Given this list of marker genes CTCFL, MED13L, GNA13, LETMD1, ATP8A1, SLC39A10, UBE3A, LRRC15 (leucine rich repeat containing 15), ZNF207 (NCBI Gene Id 7756), TTLL2, SERTAD2, RPRD1A, FHOD3, CAMTA1, ERBIN, SZRD1, NARS1, TGFB1, NALF1, GPAM, CHPF, MIB1, ZNF619, DNER, FGFR1, TSHZ1, CNTN1, FCGR1BP, FGD5, FCGR1A, PKM, CSTF2T, INPP5A, CDHR4, TMEM127, CXXC4, TXK, SHC1, RUFY3, PPP2R5E, STRBP, RBM39, HOMER2, KBTBD8, CTCF, FAM131B, CHP1, RPGRIP1L, ANKRD26, ELOVL1, TMEM25, PTPRO, CNTNAP2, NXPH1, CCDC142, TMEM64, MYO18A, ZC3H11A, CDKL1, ALS2CL, NCMAP, CACNB4, UNC5C, VPS26B, RBL2, KSR2, CALN1, SUFU, ZC3H7A, here is a description of the gene set: studied in species Homo sapiens Genes predicted to be targets of miRBase v22 microRNA hsa-miR-6856-3p in miRDB v6.0 with MirTarget v4 prediction scores > 80 (high confidence targets). Human Gene Set: MIR6856_3P from publication Chen Y, Wang X (PMID 31504780)